The following is a description of a gene set: studied in species Homo sapiens Human Gene Set: GOCC_FC_RECEPTOR_COMPLEX A protein complex composed of a subunit or subunits capable of binding the Fc portion of an immunoglobulin with additional signaling components. The complex functions as a receptor for immunoglobulin., and this is the list of marker genes: CD247, LILRA4, FCER1G, FCGR3A, MS4A2